Given this list of marker genes S100B, MAPK3, APP, SAA1, CAPZA1, S100A12, MAPK1, LGALS3, HMGB1 (high mobility group box 1), CAPZA2, AGER, PRKCSH (NCBI Gene Id 5589), DDOST, here is a description of the gene set: Human Gene Set: REACTOME_ADVANCED_GLYCOSYLATION_ENDPRODUCT_RECEPTOR_SIGNALING species: Homo sapiens Advanced glycosylation endproduct receptor signaling